The following is a description of a gene set: Mouse Gene Set: GOBP_POSITIVE_REGULATION_OF_CELL_MIGRATION_INVOLVED_IN_SPROUTING_ANGIOGENESIS Any process that increases the frequency, rate or extent of cell migration involved in sprouting angiogenesis. Cell migration involved in sprouting angiogenesis is the orderly movement of endothelial cells into the extracellular matrix in order to form new blood vessels contributing to the process of sprouting angiogenesis. species: Mus musculus, and this is the list of marker genes: Jcad, Srpx2, Ptgs2, Kdr, Plk2, Cib1, Vegfa, Hmox1, Rhoj, Hdac7, Fgf2, Nrp1, Map3k3, Tgfbr3, Fgfbp1, Anxa1, Akt3, Gata2, Abl1, Pik3c2a, Foxc2, Hdac9